The following is a description of a gene set: Human Gene Set: GSE21670_UNTREATED_VS_IL6_TREATED_CD4_TCELL_DN studied in species Homo sapiens STAT3, an essential transcription factor with pleiotropic functions, plays critical roles in the pathogenesis of autoimmunity. Despite recent data linking STAT3 with inflammatory bowel disease, exactly how it contributes to chronic intestinal inflammation is not known. Using a T cell transfer model of colitis we found that STAT3 expression in T cells was essential for the induction of both colitis and systemic inflammation. STAT3 was critical in modulating the balance of T helper 17 (Th17) and regulatory T (Treg) cells, as well as in promoting CD4+ T cell proliferation. We used chromatin immunoprecipitation and massive parallel sequencing (ChIP-Seq) to define the genome-wide targets of STAT3 in CD4+ T cells. We found that STAT3 bound to multiple genes involved in Th17 cell differentiation, cell activation, proliferation and survival, regulating both expression and epigenetic modifications. Thus, STAT3 orchestrates multiple critical aspects of T cell function in inflammation and homeostasis. Genes down-regulated in CD4 T cells: medium versus IL6. from publication Durant L, Watford WT, Ramos HL, Laurence A, Vahedi G, Wei L, Takahashi H, Sun HW, Kanno Y, Powrie F, O'Shea JJ (PMID 20493732), and this is the list of marker genes: LIPA, IRF4, ACAP1, ARHGAP4, PREX1, ENTR1, FUT11, LRRC8A, PACS2, TRIM36, CAMTA1, DAXX, HABP4, STAMBPL1, SIRT7, SIPA1L1, ZNF292, EEIG1, PARP16, THEMIS, ATRAID, ARHGAP45, SPPL2A, UBA7, PACS1, IDNK, PDE4B, CD200R1, EFNA4, LIMD2, SESN3, CXCR4, SMURF2, IKZF1, ATP8B4, OS9, CHIC1, NSD3, MAP2K6, SYNJ2BP, SLC26A2, EVI2A, RRM2B (NCBI Gene Id 50484), SLC16A5, XYLT2, TESC, XPC, KCNA3, CPT1A, ZNF471, CAMKMT, IFNGR2, SLC14A1, ZBTB11, IDS, ARHGEF11, INPP5B, SLC35B3 (solute carrier family 35 member B3), HDHD5, SAMD8, ARHGAP9, PIK3IP1, RABGGTA, NPRL2, PCNX3, POLR3GL, RAB33B, LFNG, ARPC4, PHTF1, RNPEPL1, ITPKB, CHTOP, BCL2L12, KDM2A (lysine demethylase 2A), PELI1, SMC6, SMPD5, BBS2, GPR146, EPHB6, RNF32, IKBKE, RASGRP1, GALNT2, TAF7, IL6R, INO80, SIPA1, ARID1A, L1CAM, PSENEN, EVI2B, RAB8A, PHF20L1, TUT7, MIA2, UGCG, PI4KB, SGK3 (serum/glucocorticoid regulated kinase family member 3), TLR6, UCKL1, TMEM243, IRAK2, NMB, ITPRIP, SP4, PBX2, ZBTB12, ARHGAP29, ITPR3, CCL5, ABCG1, UBE2D3, ITGB7, RBM39, ASAP1, USE1, CXXC1, GATAD2A, APBB1IP, C19orf38, TSPAN32, CYP2S1, PLCL2, STK38, RGL2, MAP4K5, TCF7, IFNAR1, ITCH, NFIC, MRPL24, ABCB9, KIAA2013, ZNF592, EDEM3, KIF21B, SBF1, CDKN1B, CNN2, ATXN1L, CBX7, WLS, PPIL4, TNRC6B, PITPNM1, DCAF15, ALDH4A1, EIF4A2, CLCF1, AAK1, BSCL2, PIP4K2A, HS3ST3B1, NIPBL, SPIN1, TAOK1, H2BC18, C15orf61, PARP6, ZNF398, ZNF563, KLHDC1, TLR1, PDCD4, TTYH3, RAP1GDS1, CYTIP, BBS9, CAMK2G, ACVR1B, SMAD4, SPO11, TAFAZZIN, DSE, RB1CC1, RARA, C6orf62, CACNA2D4, PITPNC1, MEF2D, BCL11B, VPS13D, CD8B, SLC41A3, SENP6, ATP8A1, PDLIM1, CRIM1, EVL, ENTREP3, TMEM81, LRATD2 (LRAT domain containing 2), RASAL3, NMI, KREMEN1, CD74, SYNE1, DCTN5